Given this list of marker genes H1f1, Kpnb1, Hmgb2, H1f0, H1f2, Hmgb1, H1f4, Kpna1, Casp3, H1f5, Dffb, Dffa (NCBI Gene Id 13347), here is a description of the gene set: species: Mus musculus Mouse Gene Set: REACTOME_APOPTOSIS_INDUCED_DNA_FRAGMENTATION Apoptosis induced DNA fragmentation